Given this list of marker genes ERCC6, WARS2, FMR1, IFRD1, GGT1, CTDP1, SCN1A, PITRM1, AMACR (alpha-methylacyl-CoA racemase), HIBCH, FBXO7, TGM6, UFC1, REEP2, TK2, KNSTRN, MT-ND5, KCNJ10, ALS2 (NCBI Gene Id 65058), QRICH1, MT-ND4, TPP1, SPG11, CACNA1C, TMEM240, RTN2, GABRA1, CSTB, UCHL1, NR4A2, NPTX1, NOTCH2NLC, TMEM63A, KCNK4, YWHAG, SCN2A, MT-CYB, VAPB, CAMTA1, ATXN2, LEMD2, GSS, KARS1, MAOA, VWA3B, NDUFS2, CYP7B1, SLC19A3, NKX6-2, UROC1, SLC25A46, NIPA1, SACS (NCBI Gene Id 26278), SCN1B, LAMA1, THG1L (tRNA-histidine guanylyltransferase 1 like), NGLY1, ATM, ATN1, DNAJC30, PRICKLE1, LMAN2L (NCBI Gene Id 84746), NFASC, TBP, TPK1, TENM4, COQ4, ABHD12, MT-ND1, TUBB4A, MRE11, KCNN2, SEMA6B, JPH3, GABRG2, TH, HSD17B4, EPRS1, TSPOAP1, MT-CO3, TMCO1, HMBS, ALDH18A1, BRAT1, GTF2E2, FARS2, SPTBN1, GJB1, POU4F1, ANO3, SCP2, AFG3L2, PSAP, SIGMAR1, PMP22, PPP1R15B, OPA3, PIGA, SCARB2, PRDX3 (peroxiredoxin 3), PCDH19, GCH1, NONO, PLP1, HYCC1, TMEM70, PRKN, GRIK2, GALT, ARSA, WDR81, PRKRA, SPTLC1, MYBPC1, MT-ATP6, CCDC88C, GJC2, COL6A3, TMEM106B, PPP2R2B, POLG, OPHN1, MAG, PI4KA, PIK3CA, EIF2AK2, MPZ, KCND3, ATCAY, CARS1, FUS, RNF113A, NDRG1, FGF14, FXN, HSPD1, ITPR1, POLR3B, MPLKIP, CWF19L1, POLR3A, SETX, DNAJC19, MT-ND2 (NCBI Gene Id 4536), TECR, RNU12, ABCB7, MT-CO1, PARK7, MT-ND4L, GTF2H5, SCN9A, SLC9A1, PIK3R5, TTR, LMNB1, MFN2, SPTBN2, ATP6AP2, RFC1, COQ2, NKX2-1, RARS1, ADPRS, CACNA1A, ANO10 (NCBI Gene Id 55129), PIK3CD, ATXN1, DRD3, XPNPEP3, CARS2 (cysteinyl-tRNA synthetase 2, mitochondrial), ERCC3, SCYL1 (SCY1 like pseudokinase 1), VPS13A, ELOVL4, SNCA, CLCN2, ITM2B, KIF1C, ACBD5, ERCC8, AKT1, ATXN10, PTEN, VLDLR, PLA2G6, TARS1, NOP56, PNPLA6, AARS1 (NCBI Gene Id 16), STUB1, SMG9, BSCL2, MT-ND6, FLVCR1, TPR, PTRHD1, PMM2, PDGFB, RILPL1, NOL3, KCNC3, ATP13A2, ERCC2, POLR1A, ATP2B3, SLC30A10, TTPA, IMPDH2, CACNA1G, PEX10, here is a description of the gene set: Human Gene Set: HP_ACTION_TREMOR Action tremor studied in species Homo sapiens A tremor present when the limbs are active, either when outstretched in a certain position or throughout a voluntary movement.